The following is a description of a gene set: Mouse Gene Set: GOBP_APOPTOTIC_PROCESS_INVOLVED_IN_HEART_MORPHOGENESIS species: Mus musculus Any apoptotic process that contributes to the shaping of the heart., and this is the list of marker genes: Foxc2, Ccn1, Bmp4, Tgfb2, Hand2, Foxc1, Nkx2-5